Given this list of marker genes Gm18128, Pop4, Prrg2, Misfa, Vrk3, Gm5896, Gm21122, Prmt1, Gm25405, Gm18706, Tmem143, Zfp975 (NCBI Gene Id 434179), Gm7224, Gm9244 (predicted gene 9244), Gm9246, Gm24797, Mir7055, Mir150, Gm21276, Ntn5, Gm9860, Lmtk3, Klk1b24, Gm28453, Clec11a, Ruvbl2, Gm10351, Fuz, Napsa, Saa3, Gm9712, Dbp, Vmn2r-ps56, Siglecf, Vmn2r63, Akt1s1, Ccnb1-ps, Gm29258, Gm25784, Gm7211, Klk15, Cd37, Snord35a, AI987944, Gm10252, Klk6, Spty2d1, Zfp977, Spaca4, Gm36864, Mir7056, Josd2, Gm1982, Gm9392, Klk1b12-ps, Klk1b26, Gm22203, Tbc1d17, Acp4, Gm32031, Zfp536, Gm4884, Bax, Gm7255, Snord34, Gm6819, Zfp939, Siglecl2, Zfp175, 1700110I07Rik, Ppp1r15a, EU599041, Gm6818, Gm21136, Gm1988, Gm14377, Rras, Klk1b4, Ptpn5, Gm6866, Ppfia3, 5430431A17Rik, Tmem86a, Uri1 (URI1, prefoldin-like chaperone), Topbp1-ps1, Gm17791, Gys1, Rpl14-ps1 (ribosomal protein L14, pseudogene 1), Etfb, Klk1b8, Fam83e, Mrgpra2a, Gm5114, Gm7238, Zfp715, Gm23991, Klk1, Ldhc, Klk1b28-ps, Gm2381, Myod1 (myogenic differentiation 1), Misfadt, Lin7b, Gm45173, Gm9271, Emc10, Saa4, Klk1b19-ps (kallikrein 1-related peptidase b19, pseudogene), Rps11, Nomo1, Mrgprx3-ps, Gm9294, Klk5, Tulp2, Gm5591, Kash5, Dkkl1, Klk1b22, Lrrc4b, Kcnj11, Gm23103, Kcnj14, Pih1d1, 4930505M18Rik, Klk11, Gm15517, Vmn2r60, Klk1b21, Siglecl1, Mir7054, Tead2, Klk1b1, Bcat2, Gm28583, Gm2021, 4933421I07Rik, Mir5121, Gm28455, Fgf21, Klk9, D7Bwg0826e, Myh14, Mrgprc4-ps, Ceacam18, Mrgprc1-ps, Ntf5, Car11, Klk1b3, Irf3, A230077H06Rik, Gm31597, Gm6004, Klk2-ps, Aspdh, Gm36546, Aldh16a1, Kcnc3, Zfp936, Vmn2r62, Gm2308, Gm4451, Gm17768, Emp3, Syngr4, Scaf1, Zfp619, Gm52993, Gm28581, Mrgpra3, Gm15396, Med25, Gm20749, Gm21129, 1600014C10Rik, Nosip, Gm31941, Klk12, Gm16387, Gm6124, Zfp473, Gm10298, Vmn2r58, Mrgpra2b, Gm2128, Mrgpra9, Gm21115, Plekhf1, Vmn2r59, 1700025L06Rik, Tph1 (NCBI Gene Id 21990), Snrnp70, Sec1, Otog, Nr1h2, Izumo1, AW146154, Gm9220, Gm19248, Gm5592, Prr12, Mtag2, Gm6820, Gm9322, Vmn2r61, Gm5331, Cd9-ps, Sergef, Gm21142, Klk14, Vsig10l, Saa-ps, Gm38997, 2410002F23Rik, Tsg101, Pth2, Ldha, Iglon5, Gm9252, Gm29791, Saa2, Gm45552, Slc6a21, Klk1b2-ps, Hsd17b14, Klk1b10-ps, Gm17983, Grwd1, Fut1, Klk10, Gm10109, Mir7051 (microRNA 7051), Nkg7, Shank1, Klk1b7-ps, Vmn2r-ps59, Syt3, Gfy, Saa1, Ap2a1, Ctu1, Gm21152, Klk1b15-ps, Vmn2r-ps58, Vmn2r-ps60, Gm29293, Klk7, Cpt1c, Mamstr, Lhb, Mybpc2, Gm26327, Klk1b11, Kdelr1, Kcnc1, Rasip1 (Ras interacting protein 1), Pold1, 4933402C06Rik, Mir7052, Gtf2h1, Flt3l, Mir707, Pin4-ps, Nup62, Uevld, Gm18307, Trpm4, Sphk2, Hrc, Lim2, Nucb1, Mrgpra6, Atf5, Gm9226, Klk1b23-ps, Gm17102, Fut2, Bcl2l12, Odad1, Klk1b18-ps, Klk8, Gm6872, 4933404I11Rik, 2310016G11Rik, Fcgrt, Mrgpra1, Snord32a, 1700010N08Rik, Pnkp, Dhdh, Slc17a7, A030001D20Rik, Rcn3 (NCBI Gene Id 78587), Cd33, Il4i1, Spib, Gm22302, Gm9278, Siglecg, Ptov1, Mir7053, Gm38999, Gm33989, Gm15470, Siglece, Gm2108, Klk1b16, Gm19246, Zfp141, Vmn2r-ps57 (NCBI Gene Id 12375), Gm4454, Vmn2r57, Snord35b, Saal1, Grin2d, 1700008O03Rik, Klk1b27, Garin5a, 1700028J19Rik, Gm17067, Kcna7, Gm9239, Gm9266, Klk1b14-ps, Slc6a16, Gm5590, Zfp719, Gm18905 (predicted gene, 18905), Rpl13a, Hmgb1-ps7 (high-mobility group high mobility group box 1, pseudogene 7), Vstm2b, 0610005C13Rik, 4930433I11Rik, Gm23585, 2610021A01Rik, Gm31479, Ush1c, Mrgpra14, Rpl18a-ps4, Gm30684, Gm9230 (predicted gene 9230), Gm6871, Ccne1, Hps5, D530033B14Rik, Gm30771 (NCBI Gene Id 102632789), Sult2b1, Klk1b9, Vmn2r-ps54, Gm6887, LOC102637012, Vmn2r-ps55, 6530437J22Rik, Gm45441, Vmn2r-ps158, Abcc8, Zfp976, Gm18256, Gm2058, Plekha4, Cldnd2, Zfp819, Rpl18, 2310002F09Rik (RIKEN cDNA 2310002F09 gene), Zfp788, Ftl1, Klk1b5, Klk4, Izumo2, Gm5594, Gm15545, Gm26247, Abcc6, Klk13, Cyth2, Gm6605, Tsks, here is a description of the gene set: studied in species Mus musculus Mouse Gene Set: chr7B3